Given this list of marker genes Fgf10, Ctnnb1 (NCBI Gene Id 12387), Ptf1a, Hes1, Rbpj (NCBI Gene Id 791349), Kat2b, Mir495, Pdx1, Nkx6-1, Rbpjl, Prox1, Mir145a, Notch1, here is a description of the gene set: Mouse Gene Set: WP_PTF1A_RELATED_REGULATORY_PATHWAY Ptf1a related regulatory pathway studied in species Mus musculus